Given this list of marker genes WNT4, PORCN, TMED5, WNT5B, WNT9A, WNT16, WNT2, WNT10B, WNT6, VPS26A, WNT8A, WNT7A, WNT3, VPS35, WNT11, SNX3, WNT10A, WNT7B, WNT3A, WNT9B, WLS, VPS29, WNT5A, WNT8B, WNT1, WNT2B, here is a description of the gene set: Human Gene Set: REACTOME_WNT_LIGAND_BIOGENESIS_AND_TRAFFICKING species: Homo sapiens WNT ligand biogenesis and trafficking